Given this list of marker genes ENTPD6, ENTPD1, ENTPD7, ENTPD2, ENTPD8, ENTPD4, ENTPD3, ENTPD5, here is a description of the gene set: The ectonucleoside triphosphate diphosphatase (E-NTPDase family) of ectonucleotidases includes 8 enzymes: NTPDase1 (encoded by the ENTPD1 gene), NTPDase2 (encoded by the ENTPD2 gene), NTPDase3 (encoded by the ENTPD3 gene), NTPDase4 (encoded by the ENTPD4 gene), NTPDase5 (encoded by the ENTPD5 gene), NTPDase6 (encoded by the ENTPD6 gene), NTPDase7 (encoded by the ENTPD7 gene) and NTPDase8 (encoded by the ENTPD8 gene). NTPDases hydrolyze nucleoside triphosphates and nucleoside diphosphates, producing the corresponding nucleoside monophosphates as final products. Different family members show different specificity for particular nucleotides. NTPDases are involved in various biological processes, such as hemostasis, immune response and development of the nervous system. <br>The catalytic domain of NTPDases is contained within the loop formed by a cluster of apyrase conserved regions (ACRs). All family members require divalent cations, such as calcium (Ca2+) or magnesium (Mg2+) ions, for catalytic activity. The hydrolysis involves a nucleophilic attack of a water molecule on the terminal phosphate of a nucleotide substrate.<br>All E-NTPDase family members are transmembrane proteins, associated with either plasma membrane (NTPDase1, NTPDase2, NTPDase3 and NTPDase8) or organelle membranes (NTPDase4 and NTPDase7). Two family members, NTPDase5 and NTPDase6, can be secreted into extracellular space following a proteolytic cleavage from the plasma membrane. NTPDases hydrolyze exocytoplasmic nucleotides, thus regulating the availability of ligands for purinergic receptors. Glycosylation and oligomerization are involved in the regulation of NTPDases, but have not been thoroughly studied.<p>For reviews of the NTPDase family, please refer to Robson et al. 2006 and Zimmermann et al. 2012. Reactome Pathway: Phosphate bond hydrolysis by NTPDase proteins part of: Nucleotide catabolism species: Homo sapiens